Given this list of marker genes PLSCR4, CDK10, FERMT3, KCTD14, VKORC1, TMED4, DYNLT3, ENDOV, PER3, GATA2, NOTCH2, DEF8 (differentially expressed in FDCP 8 homolog), TATDN3, ANGPT1, RNF149, POLG2, BTNL9, CHST11, F2R, FKBP9, LDLRAP1, RIOK2, ZBTB8A, MID2, PITPNC1, ADCK2, NADSYN1, SLC66A2, TBC1D24, HSD3B7, SMO, SEMA4G, PLD1, TMEM181, DDHD2, MCEE, FNIP2, NTPCR (nucleoside-triphosphatase, cancer-related), GPX1, FRRS1, MFSD12, MKRN1, GSTZ1, PAM, RBM45, NIT1, TSPAN9, SNX15, KHK, HLA-B, RPL12, P2RY4, TXK, MAPK10, OCRL, BAHCC1, METTL21A, MID1, EPHA4 (EPH receptor A4), VAT1L, DNAJC6, C6orf141, SQOR, EEF1B2, JPH3, ANGPTL4, ARHGAP23, MIDEAS, KISS1R (KISS1 receptor), PUS7L, CRTAP, RGS18, BGN, G6PD (glucose-6-phosphate dehydrogenase), CLIP4, CCDC40, SLC24A3, CHMP4B, NFE2, SARAF, GRM3, EEF1AKMT1, TPST2, CLEC3B, GSTT1, BLOC1S3, ADAT1, GALNT6 (polypeptide N-acetylgalactosaminyltransferase 6), SLC30A8, SVIP, CPQ, NEAT1, LGALS3BP (NCBI Gene Id 3959), RAB37, TRMT112, URGCP, ARHGEF4, MED22, CRYZ, RSAD1, PTPN3, LIPT2, IFIH1, NIBAN2, MACROD1, IFTAP, NME4, SDF2, DMWD, KCNH7 (NCBI Gene Id 90134), SUOX, ZNF202, RAB38, ZKSCAN1, RPS10, ARHGAP6, CSF3, WAPL, CYB5A, TADA3, VAMP8, SNHG8, PEX11A, SPATA31F1 (NCBI Gene Id 259308), KICS2, CHID1, SPINT2, DMRT3, GCNT1, MEAK7, CYP20A1, TTC36, TPK1, CYB5R1, FKBPL, ZFP2, GAA, ARHGEF25 (Rho guanine nucleotide exchange factor 25), PBX3, REC8, GLRA1, ZNF623, SLC22A3, NRK, TTC3, TEAD1, LMO2, ZNF566, TEX29, TNS1, TMEM40, SAMHD1, PRR13, DCTN6, DOCK5 (NCBI Gene Id 80005), FYB1, PAFAH2, NTMT1 (N-terminal Xaa-Pro-Lys N-methyltransferase 1), STARD10, SLC39A11, AFDN, PTER, TNFAIP6, BSCL2, TAL1, C3orf33, CTTN, FUCA1, ABHD11, GET1, OSBPL3, AVPI1, MUC13, VWA3A, DHRS11, ADCY7, NFIX, IQCH, SYCE2, EXOC6, TEX2, FAM110B, TUSC1, IL31RA, ZBTB45, LETMD1, TMEM87A, SERPINB9, STX3, IMMP2L, SNHG12, BFAR, G6PC3, ABCC4 (ATP binding cassette subfamily C member 4 (PEL blood group)), TMEM230, CD44, PARD6B, ABCA7, ENTPD6, here is a description of the gene set: Genes down-regulated in CD4 follicular helper T cells (Tfh) with SH2D1A knockout versus non-Tfh cells with SH2D1A knockout. studied in species Homo sapiens Human Gene Set: GSE21379_TFH_VS_NON_TFH_SAP_KO_CD4_TCELL_DN CD4 T cell help is critical for both the generation and maintenance of germinal centers, and T follicular helper (TFH) cells are the CD4 T cell subset required for this process. SAP (SH2D1A) expression in CD4 T cells is essential for germinal center development. However, SAP-deficient mice have only a moderate defect in TFH differentiation as defined by common TFH surface markers. CXCR5+ TFH cells are found within the germinal center as well as along the boundary regions of T/B cell zones. Here we show that germinal center associated T cells (GC TFH) can be identified by their co-expression of CXCR5 and the GL7 epitope, allowing for phenotypic and functional analysis of TFH and GC TFH populations. Here we show GC TFH are a functionally discrete subset of further polarized TFH cells, with enhanced B cell help capacity and a specialized ability to produce IL-4 in a TH2-independent manner. Strikingly, SAP-deficient mice have an absence of the GC TFH subset and SAP- TFH are defective in IL-4 and IL-21 production. We further demonstrate that SLAM (Slamf1, CD150), a surface receptor that utilizes SAP signaling, is specifically required for IL-4 production by GC TFH. GC TFH cells require IL-4 and IL-21 production for optimal help to B cells. These data illustrate complexities of SAP-dependent SLAM family receptor signaling, revealing a prominent role for SLAM receptor ligation in IL-4 production by germinal center CD4 T cells but not in TFH and GC TFH differentiation. from publication Yusuf I, Kageyama R, Monticelli L, Johnston RJ, Ditoro D, Hansen K, Barnett B, Crotty S (PMID 20525889)